Given this list of marker genes Nup62, Bicd1, Pard6a, Mark4, Apc, Gsk3b, Cep250, here is a description of the gene set: studied in species Mus musculus Any process that activates or increases the frequency, rate or extent of protein localization to centrosome. Mouse Gene Set: GOBP_POSITIVE_REGULATION_OF_PROTEIN_LOCALIZATION_TO_CENTROSOME